Given this list of marker genes MAPK1, FN1, MARK3, ACTG1, IQGAP1, RAF1, NRAS, RAP1A, VCL, MAPK3, ARAF, ITGB3, APBB1IP, CNKSR2, HRAS, ACTB, SRC, RAP1B, VWF, MAP2K1, BRAF, KSR1, CNKSR1, YWHAB, FGA, FGG (NCBI Gene Id 2266), PEBP1, KSR2, CSK, ARRB1, KRAS, MAP2K2, ITGA2B, FGB (fibrinogen beta chain), ARRB2, TLN1, here is a description of the gene set: Reactome Pathway: Signaling by high-kinase activity BRAF mutants studied in species Homo sapiens part of: Oncogenic MAPK signaling BRAF is mutated in about 8% of human cancers, with high prevalence in hairy cell leukemia, melanoma, papillary thyroid and ovarian carcinomas, colorectal cancer and a variety of other tumors. Most BRAF mutations fall in the activation loop region of the kinase or the adjacent glycine rich region. These mutations promote increased kinase activity either by mimicking the effects of activation loop phosphorylations or by promoting the active conformation of the enzyme. Roughly 90% of BRAF mutants are represented by the single missense mutation BRAF V600E. Other highly active kinase mutants of BRAF include BRAF G469A and BRAF T599dup. G469 is in the glycine rich region of the kinase domain which plays a role in orienting ATP for catalysis, while T599 is one of the two conserved regulatory phosphorylation sites of the activation loop. Each of these mutants has highly enhanced basal kinase activities, phosphorylates MEK and ERK in vitro and in vivo and is transforming when expressed in vivo. Further functional characterization shows that these highly active mutants are largely resistant to disruption of the BRAF dimer interface, suggesting that they are able to act as monomers. Activating BRAF mutations occur for the most part independently of RAS activating mutations, and RAS activity levels are generally low in BRAF mutant cells. Moreover, the kinase activity of these mutants is only slightly elevated by coexpression of G12V KRAS, and biological activity of the highly active BRAF mutants is independent of RAS binding. Although BRAF V600E is inhibited by RAF inhibitors such as vemurafenib, resistance frequently develops, in some cases mediated by the expression of a splice variant that lacks the RAS binding domain and shows elevated dimerization compared to the full length V600E mutant.